Given this list of marker genes SETMAR, ITM2C, SLC7A1, DAP3, UBE2N, PSMD12, TALDO1, MAOB, SORBS1, SLCO1B1, NR0B1, TCTN3, ABCC4, ARPC3, ECI1, HSPA1A, TPSG1, NPR2, AP3S1, GSTT2, ACVR1, IDH1, TWNK, RPL12, EIF4E2, FAT1, SMYD3, PSMA2, PRDX3, COA7, BZW2, CKS2, ABCA1, GSDME, CUTA, FAM200C, DNAJC12, USP6NL, ALAS1, ENPP2, SIL1, AMHR2, RGS10, MARCHF3, ADORA2B, MRPS10, CAPRIN1 (cell cycle associated protein 1), UTP20, TIMP3, HSPA2, MITF, ADGRL1, ITPRID2, ELOC (elongin C), GNAQ, LRRC8B, LMNB1, SCD, FCER1A, ADAMDEC1, FOSL1, LAGE3, FKBP9, LMO4, SSR3, PPP1R3D, TBC1D8, LMNA, TNPO3, AMPD3, TSC22D1 (NCBI Gene Id 8848), RPF1, LYL1, RTN3, PPP2CA, ABHD6, PLA2G4A, ADO, MYO1D, CMA1, MEIS2, PGK1, M6PR, MRPL42, ATP5MC3, TMSB15B, NUDT2, TAOK3, ITGA3, LRP12, SGPP1, UTP3, CERS6, GMPR (guanosine monophosphate reductase), CAMTA1, PKP4, EPB41L2, LAMP1, N6AMT1, ATP5PF, HSPE1, ZNF804A, NDRG2, ERI2, PRKCI, CHAC1, MGST2, IL1R1, EVI5, RBMY2FP, TAX1BP1, MCFD2, C1QBP, ENO3, CRISP3, SIGLEC6 (NCBI Gene Id 946), LARP1, ATP5F1A, ZNF124 (NCBI Gene Id 7678), BCAT1, NDUFA6, IDI2-AS1, HSPA4, SERINC3, RTN2, TGFA, GRB10, GLUL, ADAM9, MCTP1, KCTD3, CCT5, QPRT, RBKS, PAICS, PPM1H, ADAMTS3, RAB20, METAP2, AKAP12, FER, PPP6C, NDST2, PUM3, SOX4, DRAM1, CLTC, SOCS5, PFDN2, CLIC4, EPAS1, CPLX2, H1-0, CAMSAP2, CHMP3, TBC1D4, TRIM24, DPY19L1, NMD3, LIPA, PRDX6, ESD, RAI14, CENPU, PSMD1, PSMA3, WWC2, IPO7, ZFYVE21, PCTP, TSG101 (NCBI Gene Id 89764), STXBP1, TIGD6, ARAP3, FRY, DUSP10, LSM6, ETV5, GTF2H5, NRP1, P2RX1, OR10J1, SRPRB, MOB1A, RHOBTB3, SHMT2 (serine hydroxymethyltransferase 2), PTK2, SMS, KLHL9, TCEAL4, ZNF516, SNRPD3, NDUFA4, RSL24D1, SNN, TMEM14A, ARHGAP6, CTSV, PMEPA1, here is a description of the gene set: Genes up-regulated in comparison of mast cells versus NK cells. studied in species Homo sapiens In the present study we used Affymetrix oligonucleotide microarrays to produce gene transcription profiles for the major leukocyte types in humans. This comprehensive dataset enabled us to not only establish which genes were expressed in each leukocyte type, but also which genes were expressed in each subset after activation. The used of a comprehensive dataset of gene profiles from all the major human leukocyte subsets enabled a novel and powerful means for identification of genes associated with single leukocyte subsets, or different immune paradigms. Human Gene Set: GSE3982_MAST_CELL_VS_NKCELL_UP from publication Jeffrey KL, Brummer T, Rolph MS, Liu SM, Callejas NA, Grumont RJ, Gillieron C, Mackay F, Grey S, Camps M, Rommel C, Gerondakis SD, Mackay CR (PMID 16474395)